Given this list of marker genes ACVR2A, SPINK1, CNOT9, TRIP6, FGR, CDK9, TCF20, CASP10, LCK, AIP, PDE9A, CKMT2, ATM, PCSK7, IFT20, PTPN18, TRBC2, N4BP2L2, TP53BP1, E2F4, GAB1, CRADD, SEMA6A, BRF1, ITFG2, BAIAP2, ADGRG1, TTN, PBX3, RETREG3, EPM2AIP1, GRIN1, RRAD, JCHAIN, KMT2B, CTNND1, IL27RA, MYBL1, CD200, SLC2A1, KLRB1 (NCBI Gene Id 3820), XPC, COA1, IL32, HMGXB3, HPS1, HPN, LAT (NCBI Gene Id 27040), PHC2, PI4KA, CTSW, TNFRSF1B, VCAN, STK39, SF3B3, DGKA, CCN2 (cellular communication network factor 2), ZAP70, LRRC15, ACOT8, OR5I1, ANXA11 (NCBI Gene Id 311), AP3D1, ITGA5, BBC3, SFI1, AGPS, CASP8, here is a description of the gene set: from publication Chiaretti S, Guarini A, De Propris MS, Tavolaro S, Intoppa S, Vitale A, Iacobelli S, Elia L, Ariola C, Ritz J, Foà R (PMID 16160012) Differentially expressed genes between high vs low ZAP70 acute lymphoblastic leukemia (ALL) cases with no known molecular aberrations. studied in species Homo sapiens Human Gene Set: CHIARETTI_ACUTE_LYMPHOBLASTIC_LEUKEMIA_ZAP70 We evaluated the expression of 2 members of the Syk family, ZAP-70 and Syk, in acute lymphoblastic leukemia (ALL) samples, using data derived from a series of 33 T-ALL and 95 B-lineage adult ALL patients analyzed by oligonucleotide arrays. Of the B-lineage ALL cases, 37 were BCR/ABL+, 10 were ALL1/AF4+, 5 were E2A/PBX1+, and 43 carried no known molecular abnormality. ZAP-70 was highly expressed in T-ALL. A high ZAP-70 expression was also found in a proportion of B-lineage ALL, the highest levels being associated with the E2A/PBX1+ group and the lowest with ALL1/AF4+ cases (P <.001). A higher ZAP-70 expression was also observed in the pre-B group (P <.001). Remarkably, Syk expression was always preserved, suggesting that ZAP-70 expression is not substitutive of Syk. At the protein level, ZAP-70 was evaluated on 39 newly diagnosed ALL patients (25 adults, 14 children) and was detected in 23 cases (59%). ZAP-70 expression was consistently found in Ig mu+ cases. Evaluation of long-term outcome in cases without molecular abnormalities showed that the higher levels of ZAP-70 were coupled to a higher relapse rate. In ALL, ZAP-70 expression is associated with the E2A/PBX1 rearrangement and pre-B stage and may have a prognostic role and be a candidate molecule for targeted therapies.